The following is a description of a gene set: A phase of elevated metabolic activity, during which oxygen consumption increases following a stimulus as part of an inflammatory response; this leads to the production, by an NADH dependent system, of hydrogen peroxide (H2O2), superoxide anions and hydroxyl radicals, resulting in an increase in their intracellular or extracellular levels. species: Homo sapiens Human Gene Set: GOBP_RESPIRATORY_BURST_INVOLVED_IN_INFLAMMATORY_RESPONSE, and this is the list of marker genes: NCF1, LIPA, INS, PRDX2, RPS19, GRN, S100A9, DUSP10 (NCBI Gene Id 11221), SLAMF8 (NCBI Gene Id 56833), LBP